The following is a description of a gene set: electronically inferred by orthology from the curated human pathway Reactome Pathway: Tie2 Signaling species: Mus musculus part of: Cell surface interactions at the vascular wall This event has been computationally inferred from an event that has been demonstrated in another species.<p>The inference is based on the homology mapping from PANTHER. Briefly, reactions for which all involved PhysicalEntities (in input, output and catalyst) have a mapped orthologue/paralogue (for complexes at least 75% of components must have a mapping) are inferred to the other species., and this is the list of marker genes: Grb2, Pik3r2, Angpt2, Shc1, Dok2, Pik3cb, Hras, Angpt4